Given this list of marker genes MDH1, ALDOA, TUBA1A, NOTCH3, SLC25A6 (solute carrier family 25 member 6), COL4A1, ASPN, ISYNA1, MT2A, LHFPL6, COX8A, ATP6V1G1, TXNIP (NCBI Gene Id 10628), CXCL12, NDRG2, PSMB1, SDHD (NCBI Gene Id 91899), C12orf57, COX5B, TPM2 (tropomyosin 2), DLC1, NDUFB7, H3-3B, ADIRF (NCBI Gene Id 10974), LPL, EPHX1, CD36, ARHGDIB, MYO1B, MEF2C, SH3BGRL, CPM, IGFBP7, EGFLAM, CNN3, MYL9, MIR4435-2HG, SPARCL1, LAPTM4A, SERPING1, ASAH1, COX7A2, PTMS, NDUFA1, FAM162B, TIMP3, ACTA2, EFHD1, VAMP2, UBB (NCBI Gene Id 91253), ATP5F1B, PDGFRB, YWHAB, SKP1, CD9, SOD1, ATP5MC3, VDAC2, COX4I2, CALD1, CPE, TFPI, HES1, MYH9, SPARC, MCAM, TMEM50A, RGS5, MALAT1, CSNK1E, GAPDH, COL4A2, CYB5R3 (NCBI Gene Id 1727), CHCHD10, FRMD3, ITM2C, TIMP1, COX7A1, CD44, SELENOM, ESD, COX6B1, LGALS1, MT-CO1, SRI, CRIP1, TINAGL1, BSG, SLC25A5, CD151, GJA4, PEBP1, PRXL2A, TESC, TNFRSF21, SNCG, CAVIN3, MFGE8, ITM2B, EPS8, STEAP4, MT-ATP6, DPYSL2, ADISSP, ANXA5, ITGB1, NR2F2, NDUFA4L2, LDHB (NCBI Gene Id 3945), NDUFA13, COL3A1, MGST3, LEPROT, ATP5F1A, ABCC9, COL6A3 (collagen type VI alpha 3 chain), ATP5MC2, TMEM59, PDLIM1, IFITM3, PRDX1, COL6A2, COX7B, CRIP2, TECR, RABAC1, CYGB, FLNA, CYTOR, TPI1, NDUFA11, CD63, RHOB, TAGLN, PPP1R14A, SELENBP1, THBS4, KCNJ8, TPM1, EIF3K, CALM2, ATP5MK, GAS6, HIGD1B, here is a description of the gene set: studied in species Homo sapiens from publication Rubenstein AB, Smith GR, Raue U, Begue G, Minchev K, Ruf-Zamojski F, Nair VD, Wang X, Zhou L, Zaslavsky E, Trappe TA, Trappe S, Sealfon SC (PMID 31937892) Human Gene Set: RUBENSTEIN_SKELETAL_MUSCLE_PERICYTES